The following is a description of a gene set: Human Gene Set: GOBP_POSITIVE_REGULATION_OF_TRANSCRIPTION_REGULATORY_REGION_DNA_BINDING Any process that activates or increases the frequency, rate or extent of transcription regulatory region DNA binding. species: Homo sapiens, and this is the list of marker genes: NIBAN2, H1-0, POU4F1, TWIST1, GATA3, HAND2, IGF1, POU4F2, TRIM6, RB1, NEUROD1, GTF2B, DAZAP2, FOXC1, IFNG